The following is a description of a gene set: species: Mus musculus Mouse Gene Set: GOBP_DETERMINATION_OF_LEFT_RIGHT_ASYMMETRY_IN_LATERAL_MESODERM The establishment of the lateral mesoderm with respect to the left and right halves., and this is the list of marker genes: Smo, Shh, Zic2 (NCBI Gene Id 57066), Smad2, Cited2, Dand5, Nodal